The following is a description of a gene set: from publication Chen Y, Wang X (PMID 31504780) Human Gene Set: MIR552_5P Genes predicted to be targets of miRBase v22 microRNA hsa-miR-552-5p in miRDB v6.0 with MirTarget v4 prediction scores > 80 (high confidence targets). studied in species Homo sapiens, and this is the list of marker genes: USP38, FOXO1, GET1, ZNF557, TOR1AIP2, PREX2, TRIM33, LRIT3, CLIC5, USP31, NUP93, BAZ2A, RPRD2, OGDH, SUMO3, PDCD6IP (NCBI Gene Id 245794), PHIP, DNA2, CDC42EP3, MTMR9, SGIP1, AK3, RIF1, ATP6V1A, SLC2A13, EIF3J, ZNHIT6, SV2B, PALM2AKAP2, CNNM1 (cyclin and CBS domain divalent metal cation transport mediator 1), GALNTL5, DDIAS, SERINC3, ADAMTS8, PAQR3, SLF2, ELF1, DEPDC1B, VSTM2A, GPR180, RAD54L, CD28, RAB31, ATXN7, KHDRBS1, DCAF17, TSHZ3, CREB3L2, NHEJ1 (non-homologous end joining factor 1), MDFIC, GABRG1, XPO1, TAFA2, ZFYVE16, IFT80, LAMP2, BLOC1S6 (biogenesis of lysosomal organelles complex 1 subunit 6), SOCS7, HORMAD1, TMEM71, DDX4, MBNL1, CS, SPTSSA, MAP3K2, BZW1, DENND1B, TMEM129, DNAJC21, CAND1, WBP4, CHORDC1, SH3D19, ARL14EP, CEP120, RNASEH1, SMCR8, CAPZA2, EBNA1BP2, LMNTD1, KDM7A, BICD2, RASA4, PKDCC, CADM2, RASSF10, CLCA2, SLC39A8, SRSF1, NAA50, RB1, FBXO30, RANGAP1, ANKRD40, ZNF831, XRN2, CTBP1, GOLT1B, ABCD3, CLOCK, PRELID3A, BRAF, LAMP1, GPR161, EYA4, GAS2L3, KCNAB1, NECTIN3, EGR3, ELL2, SSTR1, DGKH, TMEM161B, UBE2B, YAE1, CABP5, CDC73, ITPR2, RAI14 (NCBI Gene Id 79367), TGFB2, ROR1, GHSR, UBL3, MAP2, DNAJC9 (DnaJ heat shock protein family (Hsp40) member C9), UXS1, SBDS, HYCC2, SP4, CASP7, TRIM61, C17orf78, EOLA1, MRPL19, ZBTB21, SHROOM2, AVL9, OTX2, RNF6, WIF1, KCNT2, FAM210A, EVI5, CRISP3, GPR146, DMRT1, CACNA1H, ARL13B, PTS, PGPEP1, SNRPD1, ZYG11B, REDIC1, ZBTB44, ATAD2, EBLN2, ZCCHC14, STRN, SLC12A2, SEC22A, FXR1, ADTRP, SPEF2, GNPDA2, DNAAF2, RNF103 (ring finger protein 103), LIN9, SLAIN2, FGF13, MTMR10, DOK6, TRAPPC13, COPRS, ERRFI1, ASAP2, TOB1, IFIT5, KIAA0319, NDFIP2, CRY1, MAPK14, TRPS1, CDK17, PJA2, NOVA1, IPO9, CCNJ, DSC3, PIK3R1